The following is a description of a gene set: from publication Olex AL, Hiltbold EM, Leng X, Fetrow JS (PMID 20682054) Genes up-regulated in bone marrow-derived dendritic cellstreated by poly(IC): 3h versus 24h. Human Gene Set: GSE21033_3H_VS_24H_POLYIC_STIM_DC_UP BACKGROUND: Dendritic cells (DC) play a central role in primary immune responses and become potent stimulators of the adaptive immune response after undergoing the critical process of maturation. Understanding the dynamics of DC maturation would provide key insights into this important process. Time course microarray experiments can provide unique insights into DC maturation dynamics. Replicate experiments are necessary to address the issues of experimental and biological variability. Statistical methods and averaging are often used to identify significant signals. Here a novel strategy for filtering of replicate time course microarray data, which identifies consistent signals between the replicates, is presented and applied to a DC time course microarray experiment. RESULTS: The temporal dynamics of DC maturation were studied by stimulating DC with poly(I:C) and following gene expression at 5 time points from 1 to 24 hours. The novel filtering strategy uses standard statistical and fold change techniques, along with the consistency of replicate temporal profiles, to identify those differentially expressed genes that were consistent in two biological replicate experiments. To address the issue of cluster reproducibility a consensus clustering method, which identifies clusters of genes whose expression varies consistently between replicates, was also developed and applied. Analysis of the resulting clusters revealed many known and novel characteristics of DC maturation, such as the up-regulation of specific immune response pathways. Intriguingly, more genes were down-regulated than up-regulated. Results identify a more comprehensive program of down-regulation, including many genes involved in protein synthesis, metabolism, and housekeeping needed for maintenance of cellular integrity and metabolism. CONCLUSIONS: The new filtering strategy emphasizes the importance of consistent and reproducible results when analyzing microarray data and utilizes consistency between replicate experiments as a criterion in both feature selection and clustering, without averaging or otherwise combining replicate data. Observation of a significant down-regulation program during DC maturation indicates that DC are preparing for cell death and provides a path to better understand the process. This new filtering strategy can be adapted for use in analyzing other large-scale time course data sets with replicates. species: Homo sapiens, and this is the list of marker genes: CMAHP, INPP5D, POMC, FAM161B, GCOM1, PARP3, LCP2, IL21R, PLXND1, LINGO4, IKZF3, HELZ2, RREB1, FBXW10, PPP1R13B, FMNL2, MIR32, ATP1B1, CEP295NL, CBFA2T3, TRPV2, SEMA7A, BCAT2, PLA2G6, DGKD, SPATA31F3, DOCK2, OTUD1, FAM24A (family with sequence similarity 24 member A), LDLRAD3, AFTPH, AFF3, RAB5A, CABYR, HELZ, LRIG1, SLC12A6, AGO1, ITPR1, RANBP10, IDH2, PFKFB3, BCL2L1, DNAI7, RGS14, VAMP1, PLXDC1, NTRK3, NTN1, PPFIBP2, KLF13, SLC9A5, NSD3, TMEM184B, SPG11 (NCBI Gene Id 80208), GFI1, SPATS2L, UTP25, LZTS2, SEMA4D, PATJ, VARS2, BAZ2A, MBNL1, KDM4B, ODF4, GBP4, FBXL17, TGFBR3, RNF24, LLGL2, DNAJB7, DNAJC3, CEP120, ARFGAP1, CTSL, PRRC2C, UCK2, AHDC1 (NCBI Gene Id 27245), C16orf54 (chromosome 16 open reading frame 54), IL17RE, DNAJC6, PPP1R16B, SCN4B, H19, DIDO1 (NCBI Gene Id 85362), MBNL2, MAB21L2 (NCBI Gene Id 10586), CHRNA2, TBC1D2B, COLEC11, USP7, IP6K2, ARHGAP26, USPL1, RAD9B, PSAP, PREX1, GTF2IRD1, INSR, FBXL9P, RNF169, TNRC6B, MAPK8IP3, GUCY1A1, WDFY2, AK3, PPT2, ZFP36, CYSLTR1, LCA5, DPY19L3, TTPAL, LRRC1, GRK2, PIK3R5, RGP1, TAB2, LNPEP, MYO10, POLR2A, PIAS3, REC8, KDM4C, FEM1A, TNIP1, WHRN, IL16, DUSP7, TRIM24, FKBP1A, SCMH1, CACNB1, MEF2A, SUPT5H, TECPR1, EXOC2, CLDN4, ARHGAP31, PRODH, PAN3, SLC4A5, PDPK1 (NCBI Gene Id 5170), MIR106A, LORICRIN, PVR, VPS37B, ITGA6, ZNF250, MLLT10, TBC1D8, RCSD1, F13A1, MAD1L1, SATB1, SNCB, TTC17 (NCBI Gene Id 55761), SYNPO, MBP, FNBP1, VAV2, ITK, NCOA6, REEP4, EML5, MAP3K8, PDE8A